Given this list of marker genes Ppp2ca, Mapk14, Rps6ka3, Mapk3, Ppp2cb, Dusp4, Dusp7, Atf1, Ppp2r1b, Mapk1, Dusp3, Ppp2r5d, Ppp2r1a, Fos, Jun, Creb1, Mapk9 (mitogen-activated protein kinase 9), Rps6ka5, Mapkapk2, Rps6ka2, Mapk7, Mapk11, Mapk10, Vrk3, Mapk8, Rps6ka1 (NCBI Gene Id 230803), Atf2, Dusp6, here is a description of the gene set: MAPK targets/ Nuclear events mediated by MAP kinases Mouse Gene Set: REACTOME_MAPK_TARGETS_NUCLEAR_EVENTS_MEDIATED_BY_MAP_KINASES species: Mus musculus